Given this list of marker genes Gimap5, Metrnl, Klrb1b, Apobec3, Ifngr1, Tnfrsf9, Celf2, Arap2, Sh2d2a, Emb, Crem, Prdx6, Fth1, Tmem106b, Tsc22d3, Litaf, Cenpa, Hsh2d, Fam107b, Irak2, Sult2b1, Mt1, Epb41 (erythrocyte membrane protein band 4.1), Mosmo, Serpina3g (NCBI Gene Id 20715), Abcb1a, Bcl2l11, Sipa1l1, Tnfrsf18, Itgb3, Abcb1b, Il2rb, Ndrg1, Srgn, Serpinb6b, Hvcn1, P2ry10 (NCBI Gene Id 78826), Fabp5, Rnf125, Stat3, Ptpn22, Cables1, Camk4, Cytip, Dgat1, Serpinb9, Fasl, Slfn2, Gimap3, Plscr1, Fam184a, Sft2d2, Fam117b, Serinc3, Txnip (thioredoxin interacting protein), Irf8, Vps37b, Mknk2, Rnf19b, here is a description of the gene set: Cytokines mediate cell-cell communication in the immune system and represent important therapeutic targets. A myriad of studies have highlighted their central role in immune function, yet we lack a global view of the cellular responses of each immune cell type to each cytokine. To address this gap, the authors created the Immune Dictionary, a compendium of single-cell transcriptomic profiles of more than 17 immune cell types in response to each of 86 cytokines (>1,400 cytokine-cell type combinations) in mouse lymph nodes in vivo. A cytokine-centric view of the dictionary revealed that most cytokines induce highly cell-type-specific responses. For example, the inflammatory cytokine interleukin-1β induces distinct gene programmes in almost every cell type. A cell-type-centric view of the dictionary identified more than 66 cytokine-driven cellular polarization states across immune cell types, including previously uncharacterized states such as an interleukin-18-induced polyfunctional natural killer cell state. Mouse Gene Set: CUI_NK_CELL_IL1A_RESPONSE_UP Genes positively differentially expressed in cell type: NK cell upon treatment with cytokine: IL-1α in mouse lymph nodes in vivo. studied in species Mus musculus from publication Cui A, Huang T, Li S, Ma A, Pérez JL, Sander C, Keskin DB, Wu CJ, Fraenkel E, Hacohen N (PMID 38057668)